Given this list of marker genes CDK8 (cyclin dependent kinase 8), GABRA5, PSPH, PBX3, CPSF2, VPS13C, VKORC1L1, RABIF, GRM8, RB1, SLC25A31, ZNF326, FKBP7, UBE2N (ubiquitin conjugating enzyme E2 N), MCTP2, ZNF592, PAPOLA, ZC3H14, MYO1D, CREBRF (NCBI Gene Id 153222), SCN7A, SCN9A, ZNF140 (zinc finger protein 140), MIGA1, PGM3, NCBP1, AK9, YAF2, PEG3, ZNG1F, HTR1E, PPP4R3A, CA10 (NCBI Gene Id 769), XK, PAXBP1, FERRY3, DHODH, SH3RF2, ITSN1, ELAVL2 (ELAV like RNA binding protein 2), TOX3, FOXR2, PRKX, SEMA3D, TTC23L, RNF11, SMC2, NOTCH1, PHIP, RORB, ADRA1A, BRIP1, RAB33A, IL31RA, SLC7A14, CCDC88A, RORA (RAR related orphan receptor A), PIK3R6, IRS1, ZNG1C, KANK4, UTS2B, NXN, ELK4, CACYBP, MAGEB6, GALM, NEK7, MBTD1, ZBTB41, EAPP, ANKRD12, TFEC, THBS1, ICA1L (islet cell autoantigen 1 like), PRDM8, ANKUB1, ZC3H12C, SMOC2, AR, STARD4, IQSEC1, ANO4, TYW1B, LRCH1, KIF1B (NCBI Gene Id 57598), OST4, RHOBTB1, ZNG1E, SH3BGR, SAV1, TMEM47, FNDC3A, TYW1, RIMS2, KANSL1L, ZC3H6, CYP20A1, DNMT3A, GLRA3, ITPRID1, CDH11, PRDX3, DGKH, PLD5, EXOC4, CAMK1, BEND6, ZC3H12B, GNG5, SLC31A2, SLC7A11, CRISP3, RPP14, FMR1, VAPB (VAMP associated protein B and C), NHLH1, SGIP1, SLCO3A1, PNO1, COG6, LRRC7 (NCBI Gene Id 57554), ZDHHC21, PTAFR, PER1, FGB, GPALPP1, SLC22A4, ARRDC3, PNRC1, ZDHHC15, WWC2, NEUROD2, SLC35G2, PCDH17, ADGRL2, SPARC, MFAP2, CAMTA1, ATG4A, ZNF677, BIVM, DPY19L3, IGF2BP3, ADD3, MFSD4A, ALG13, GET1-SH3BGR, BCOR, EFCAB11, USP51, EPHA7, here is a description of the gene set: species: Homo sapiens Genes predicted to be targets of miRBase v22 microRNA hsa-miR-3149 in miRDB v6.0 with MirTarget v4 prediction scores > 80 (high confidence targets). Human Gene Set: MIR3149 from publication Chen Y, Wang X (PMID 31504780)